Given this list of marker genes ARPC4, PYROXD1, KDM5B, JARID2, PIGL, AUTS2, TMEM218, HOXD13, KMT2B, LIFR, GJA1, GNPNAT1, SLC29A3, FBXW11, ZDHHC9, CTCF (CCCTC-binding factor), here is a description of the gene set: species: Homo sapiens Human Gene Set: HP_JOINT_CONTRACTURE_OF_THE_5TH_FINGER Chronic loss of joint motion in the 5th finger due to structural changes in non-bony tissue. The term camptodactyly of the 5th finger is used if the distal and/or proximal interphalangeal joints are affected. Joint contracture of the 5th finger